The following is a description of a gene set: Human Gene Set: GOBP_BRONCHUS_DEVELOPMENT The biological process whose specific outcome is the progression of a bronchus from an initial condition to its mature state. This process begins with the formation of the bronchus and ends with the mature structure. The bronchus is the portion of the airway that connects to the lungs. studied in species Homo sapiens, and this is the list of marker genes: SOX9, TULP3, AGR2, SRF, TGFBR2, WNT7B, IL13, BMP4, HOXA5 (NCBI Gene Id 55953), SPDEF, ADAMTSL2